Given this list of marker genes LCK, KLRC4, CTLA4, PRTN3 (proteinase 3), IL12A-AS1, ERAP1, CCR1, DOCK11, PMM2, IL10, IL12A, NF1, MIF, IRF4, HLA-DPA1, C4A, IL23R, HLA-B, P4HA2, TNFRSF1A, IFNGR1, UBAC2, RNU7-1, FCGR2A, HLA-DPB1, LACC1, PTPN22, HBA1, NOD2, TREX1, FCGR2B, HLA-DRB1, HBA2, DNASE1, FAS, STAT4, MAF, MEFV, PRG4 (NCBI Gene Id 787), IL6, TLR4, here is a description of the gene set: studied in species Homo sapiens Human Gene Set: HP_PERICARDITIS Pericarditis Inflammation of the sac-like covering around the heart (pericardium).